The following is a description of a gene set: from publication Hernández-Vargas H, Palacios J, Moreno-Bueno G (PMID 17099726) Human Gene Set: HERNANDEZ_ABERRANT_MITOSIS_BY_DOCETACEL_4NM_DN Genes down-regulated in MCF7 cells (breast cancer, normal TP53) undergoing aberrant mitosis and necrosis after treatment wiht 4 nM docetaxel. species: Homo sapiens Among microtubule-targeting agents, docetaxel has received recent interest owing to its good therapeutic index. Clinical trials have underlined its potential for the treatment of advanced breast cancer, although little is known about its molecular mode of action in this context. We characterized the molecular changes induced by docetaxel in two well-known human breast carcinoma cell lines. Two mechanisms of action according to drug concentration were suggested by a biphasic sensitivity curve, and were further validated by cell morphology, cell cycle and cell death changes. Two to four nanomolar docetaxel induced aberrant mitosis followed by late necrosis, and 100 nM docetaxel induced mitotic arrest followed by apoptosis. Passing through mitosis phase was a requirement for hypodiploidy to occur, as shown by functional studies in synchronized cells and by combining docetaxel with the proteasome inhibitor MG132. Transcriptional profiling showed differences according to cell line and docetaxel concentration, with cell cycle, cell death and structural genes commonly regulated in both cell lines. Although p53 targets were mainly induced with low concentration of drug in MCF7 cells, its relevance in the dual mechanism of docetaxel cytotoxicity was ruled out by using an isogenic shp53 cell line. Many of the genes shown in this study may contribute to the dual mechanism by which docetaxel inhibits the growth of breast cancer cells at different concentrations. These findings provide a basis for rationally enhancing docetaxel therapy, considering lower concentrations, and better drug combinations., and this is the list of marker genes: TXNRD1, HIF1A, SDHA, TFRC, GNAI1, GPC3